Given this list of marker genes Apoc2, Apol10b, Apoc4, App, Apoh (NCBI Gene Id 11818), Pla2g7, Apol11b, Apom, Pon1, Lcat, Lipc, Saa1, Apol9b, Apoa4, Apol9a, Apoc1, Hp, Gpld1, Apoa1, Apob, Saa2, Apoc2l, Hdlbp, Apoe, Apoc3, Apol10a, Apof, Apol11a, Clu, Pltp, Saa3, Apoa5, Apol8, Apoa2, here is a description of the gene set: A lipoprotein particle with a high density (typically 1.063-1.21 g/ml) and a diameter of 5-10 nm that contains APOAs and may contain APOCs and APOE; found in blood and carries lipids from body tissues to the liver as part of the reverse cholesterol transport process. Mouse Gene Set: GOCC_HIGH_DENSITY_LIPOPROTEIN_PARTICLE species: Mus musculus